Given this list of marker genes CD84, CD300LF, CNR2 (cannabinoid receptor 2), PTPN6, ENPP3, CD300A, MILR1, FER, RABGEF1, here is a description of the gene set: Human Gene Set: GOBP_NEGATIVE_REGULATION_OF_MAST_CELL_ACTIVATION Any process that stops, prevents, or reduces the frequency, rate, or extent of mast cell activation. studied in species Homo sapiens